The following is a description of a gene set: species: Homo sapiens Renal hypoplasia/aplasia Absence or underdevelopment of the kidney. Human Gene Set: HP_RENAL_HYPOPLASIA_APLASIA, and this is the list of marker genes: ATPAF2, SDCCAG8, HS6ST1, NUP37, GLI3, OFD1, STS, CDK5RAP2, DCC, RARB, PIK3CD, RPL31, CLIP2, KNL1, CCDC141, GDF3 (growth differentiation factor 3), DISP1, GFRA1, RPL18, PPFIBP1, RAI1, IL17RD, FANCD2, ATP5F1E, TFAP2A, CEP63, RPL9, ZIC2 (Zic family member 2), ARID1B, KIF14, PHGDH, CD96, FGFR1, NCAPD3, MCPH1, PLXNA1, RPL8, GTF2I, KNSTRN, RPL15, RPS29, PAX2, XRCC4, MLXIPL, ANKLE2, RFC2, AFF3, ADA2, PPP1R15B, FANCC, RPL5, PRKACA, GLI1, NDNF, WLS, TBXT, EYA1, NIPBL, WNT9B, TMEM231 (NCBI Gene Id 79583), UMOD, ZPR1 (ZPR1 zinc finger), APC2, CCNQ (NCBI Gene Id 92002), HS2ST1 (NCBI Gene Id 9653), HIRA, PHC1, PTCH1, REN, BUD23, PIEZO2, MT-ATP8, SPRY4, H4C3, APC, RPS26, PQBP1, SEMA3A, SLX4, JMJD1C, ROBO2, NF1, SIX5, EVC2, SH2B1, STRA6, CENPF, PRKAR1A, CEP152, RET, SASS6, MFSD2A, METTL5, DSTYK, GLI2, PYCR2, FGF20, SRRM2, TCTN3, DLL1, PUF60, HSPA9, FAT4, LRP4, TSR2, ITPR1, FGF17, IDH1, CHD7, DYRK1A, FGFR3, GAS1, UBE2T, STIL, UFD1, TACR3, COMT, ARL6, MT-ATP6, FEZF1, KIF7, DLL4, SEC24C, FREM1, GPKOW, TBL2, DYNC2I1, KCNJ2, NSDHL, NSD1, MKKS, LHX1, GDF6, SALL1, B3GLCT, FLRT3, NSD2, VPS37D, TMEM270, ARX, CFTR, RREB1, LMBRD1, TBC1D24, TBX18, HOXD13, ROBO1, FGF8, LEMD3, RPS10, POR, KIAA0753, SKIC3, NCF1, DHCR7, PAX1, COPB2, GTF2IRD2, ADGRG2 (NCBI Gene Id 10149), LIMK1, HEATR3, KYNU, RPS19, CDC42, TRAPPC10, DYNC2H1, FREM2, MUC1, SUFU, ANOS1, DACT1, RPL27, DHCR24, PROK2, FOXH1, MDM2, IFT80, SIX1, WBP11, VANGL1, CIT, RPL35A (NCBI Gene Id 6165), SARS1, EIF4H, WDR19, ATP5F1A, FBLN5, TRAPPC14, NFIA, HESX1, ALKBH8, RPS15A, ITGA8, PROKR2, HRAS, GP1BB, ALDH18A1, WNT4, FANCF, SALL4, DYNC2I2, STX1A, FANCM, PRMT7, CTU2, TRRAP, IQSEC2, RPL11, INSL3, FAM149B1, SON, SEC61A1, RMND1, RPL26, FGF10, SLC30A9, STX5, FBXW11, SKIC2, BRIP1, CPLANE1, BCOR, ATN1, GNB2, SOX10 (SRY-box transcription factor 10), MCM7, KDM6A, PIK3CA, FKBP6, RPS20, MCM5, IFT27, CDK6, WARS1, ATP5F1D, TMCO1, RPS28, PDE6D, RAP1B, WDR62, RFWD3, COX14, WNT3, RPS27, SF3B4, RAD51C, RIPK4, ZMYM2, FLII, RPS17, MYOD1, FANCG, NOTCH2 (NCBI Gene Id 55574), PRKACB, PRIM1, EVC, HNF1B, DCDC2, ASPM, PALB2, HAAO, ATP5MK, TMEM67, RNU4ATAC, GTF2IRD1, ERCC6, GRIP1, KCTD1, RPS7 (NCBI Gene Id 6201), FUZ, TBX3, BRCA1, BAZ1B, H4C9, KCNJ5, MEOX1, TXNL4A, BMP4, WNT7B, FGFR2, ASXL2, MAD2L2, NADSYN1, RERE, TRPV6, TNXB, ELN, C2CD3, ANKRD17, WDR35, MBTPS2, TMEM216, TBX1 (NCBI Gene Id 7413), NODAL, TGIF1, CENPE, CEP55, FANCL, PTPN11, NCAPG2, MAX, DNAJC30, FANCI, JAG1, NAA10, RPS24, CEP135, WDR11, ZIC3, TP63 (NCBI Gene Id 8860), DCHS1, COG6, RAD51, FANCE, ERCC4, GREB1L, CEP120, FRAS1 (NCBI Gene Id 84949), PPP2R1A, INTU, GATA1, METTL27, CRIPTO, H4C5, CDON, DYNC2LI1, GATA3, NRIP1, SRCAP, PORCN, MKS1, THOC6, DUSP6, KMT2D, TOPORS, RPL35, TAF13 (NCBI Gene Id 6884), XRCC2, ARVCF, PBX1, BRCA2, DEAF1, SCAF4, CRELD1, ATRX, RAD21, GEMIN4, PPP2R3C, PIK3C2A, FANCA, SIX3, RTTN, FANCB, HMGA2, ERCC8, SF3B2, ZNF699, SHH